Given this list of marker genes Arrdc3, Tbl1xr1, Hmga2, Enpp1, Dgat2, Arid5b (NCBI Gene Id 71371), Fosl2, Bbs4, Casr, Errfi1, Ubb, here is a description of the gene set: Mouse Gene Set: GOBP_FAT_PAD_DEVELOPMENT species: Mus musculus The progression of a fat pad from its initial formation to its mature structure. A fat pad is an accumulation of adipose tissue.